The following is a description of a gene set: studied in species Homo sapiens Human Gene Set: MODULE_503 Genes in the cancer module 503., and this is the list of marker genes: CLIC4, CKB, PPP2R5C, ELL, PLPBP, DPAGT1, MARF1, TYMP, H3-3B, AUP1, LEAP2, SLC25A16, CHORDC1, WNT5B, COL16A1 (collagen type XVI alpha 1 chain), DLK1, VASH2, PPP2R5D, MKNK2, TMEM97, MPPE1, PCGF3, TNFRSF14, EID1, LIMCH1, H4C14, SLC25A37, ATG5, KLK6, LSM14A, TECPR2, LHX2, PRSS8, SETDB1, CRNKL1, PNLIP, SRP14, MECP2, TXNDC16, PTMA, EXOSC4, ACACB, RNF4, NF2 (NCBI Gene Id 654093), HYOU1, PRSS3, DBNDD1, MYLK2, OXR1, TAGLN3, FOXS1, RNF11, HGD, WWP1, SLC25A1, SLC9A1, KLHDC10 (kelch domain containing 10), SMYD5, GC, NUP54, NNT, CDC42SE2, GATM, MYO1C, MLF1, NNMT, TRIM4, RPLP2, ELK1, NINJ1, DHODH, DLL1, GLRX, KPTN, SARM1, IL1R1, CTNNAL1, CD14, CC2D2A, CCDC88A, ALG12, LIMS3, PRDM1, LAMTOR1, MTMR2, PDGFRA, BMP2, ME2, TBC1D2B, PTBP1, ZNF667, KDM5D, ADA (adenosine deaminase), PFDN4, ZNF217, SSR3, TRAF6 (NCBI Gene Id 7189), PLAUR, MYH11, RHAG, ACTA1, CCN3, NXN, MARCKS, RNASEH2C, LYN, MGAT3 (NCBI Gene Id 4248), SLC20A1, CBY1, FKBP1B, PPP4R1, GABRA2